The following is a description of a gene set: Human Gene Set: GOBP_CELLULAR_RESPONSE_TO_ALKALOID Any process that results in a change in state or activity of a cell (in terms of movement, secretion, enzyme production, gene expression, etc.) as a result of an alkaloid stimulus. Alkaloids are a large group of nitrogenous substances found in naturally in plants, many of which have extracts that are pharmacologically active. species: Homo sapiens, and this is the list of marker genes: RYR3, OPRM1, ADCY8, TRPA1, TMEM38A, ABCB1, SLC1A2, SELENON, CCNA2 (cyclin A2), RYR1, SLC34A1, SLC1A3, RAD51, MDM2, RYR2, SLC8A1, CASP6, PPP1R9B, GSTM2, CASQ2, TGM2, BLM, SPIDR, TRPV1, BCL2L1, COMT, TMEM38B, SLC1A1, RECQL5, CASP7, CACNA1S, CRHBP, CRH, CASP3, EHMT2 (euchromatic histone lysine methyltransferase 2), PPP1R1B, HTR1B